The following is a description of a gene set: studied in species Homo sapiens Anterior synechiae of the anterior chamber Adhesions between the iris and the cornea. Human Gene Set: HP_ANTERIOR_SYNECHIAE_OF_THE_ANTERIOR_CHAMBER, and this is the list of marker genes: ZEB1, COL8A2, COL18A1, PAX6, FOXE3, FOXC1, OVOL2, GRHL2, VSX1, ASPH, PITX2, CYP1B1, PXDN